The following is a description of a gene set: studied in species Homo sapiens Human Gene Set: HE_LIM_SUN_FETAL_LUNG_C3_DEFINITIVE_ERYTHROCYTE from publication He P, Lim K, Sun D, Pett JP, Jeng Q, Polanski K, Dong Z, Bolt L, Richardson L, Mamanova L, Dabrowska M, Wilbrey-Clark A, Madissoon E, Tuong ZK, Dann E, Suo C, Goh I, Yoshida M, Nikolić MZ, Janes SM, He X, Barker RA, Teichmann SA, Marioni JC, Meyer KB, Rawlins EL (PMID 36493756) Definitive erythrocyte, and this is the list of marker genes: HBA1, KRT1, HBG2, TENT5C, FECH, HBA2, SLC4A1, HEMGN, GMPR, HBQ1, YOD1, GYPB, SMOX, ALAS2, STRADB, HBM, ESPN, TRIM58, HBB, GYPA, MYL4, RUNDC3A, AHSP, CDKN2D, PHOSPHO1, HBG1, SLC14A1, EPB42